Given this list of marker genes Atg101, Son, Gdf3, Ifitm3, Fcer1g, Jchain, Atp6v1g1, Prdx2, Hcst, Cyba (cytochrome b-245, alpha polypeptide), Ffar2, S100a9, Slpi, Crip1, Tspo, Clec4a2, Rps18, Lrg1, Ngp, Vcam1, S100a8, Cd74, Lgals3, Cd52, Retnlg, S100a6, Dbi, Lcn2, Ccl6, Fxyd5, Tyrobp, Cd9, H2-D1, Rsrp1, Malat1, Ifitm6, Camp, Ms4a3, Pglyrp1, Rbm3, Ifitm2, Rps19, Mrgpra2b, Ltf, Mcemp1, Wfdc21, Dmkn, here is a description of the gene set: Mouse Gene Set: TABULA_MURIS_SENIS_MARROW_NAIVE_T_CELL_AGEING studied in species Mus musculus from publication Tabula Muris Consortium (PMID 32669714)